Given this list of marker genes Ap2s1, Fzd2, Ap2m1, Ap2a1, Cltb, Ap2b1, here is a description of the gene set: species: Mus musculus This event has been computationally inferred from an event that has been demonstrated in another species.<p>The inference is based on the homology mapping from PANTHER. Briefly, reactions for which all involved PhysicalEntities (in input, output and catalyst) have a mapped orthologue/paralogue (for complexes at least 75% of components must have a mapping) are inferred to the other species. part of: PCP/CE pathway Reactome Pathway: WNT5A-dependent internalization of FZD2, FZD5 and ROR2 electronically inferred by orthology from the curated human pathway